The following is a description of a gene set: This event has been computationally inferred from an event that has been demonstrated in another species.<p>The inference is based on the homology mapping from PANTHER. Briefly, reactions for which all involved PhysicalEntities (in input, output and catalyst) have a mapped orthologue/paralogue (for complexes at least 75% of components must have a mapping) are inferred to the other species. electronically inferred by orthology from the curated human pathway studied in species Mus musculus part of: Clathrin-mediated endocytosis Reactome Pathway: Cargo recognition for clathrin-mediated endocytosis, and this is the list of marker genes: Grb2, Epn1, Cltb, Apob, Grk3, Ldlr, Stam, Avpr2, M6pr, Cd3g, Nedd8, Avp, Igf2r, Syt9, Ubb, Cbl, Ap2b1, Itsn1, Rps27a, Tor1a, Sh3gl3, Arrb2, Syt1, Cops6, Ap2s1, Necap1, Areg, Syt8, Reps1, Epgn, Slc2a8, Fcho2, Snap91, Eps15l1, Tacr1, Dvl2, Ap2m1, Vamp2, Egfr, Vamp4, Fzd4, Ubqln2, Chrm2, Tgfa, Trf, Picalm, Vamp8 (vesicle-associated membrane protein 8), Btc, Ap2a1, Cd3d